Given this list of marker genes Pfkfb2, Slc7a15, Csnk1d, Adam17, Prmt2, Dhrs11, Vat1, Adgre4, Pom121 (nuclear pore membrane protein 121), Zfp956, 2410004B18Rik, Fbln1, Acly, Spo11, Ifnlr1 (interferon lambda receptor 1), Mbd6, Strn, Rbm33 (NCBI Gene Id 72420), Polk, Zfp329, Arhgap21, Pxk, Snn, Vdac2, Tbc1d5, Acad11, Rassf8, Cks2, 2610008E11Rik, Atxn7l1, Arfgef1, Kalrn, Tmpo, Fiz1, Phf21a, Luc7l3, Wee1, Lypd6, Jak1, Mia3 (NCBI Gene Id 98575), Vkorc1l1, Abt1, Shisa8, Bnipl (BCL2/adenovirus E1B 19kD interacting protein like), Spred3, Cdkl2, Ebna1bp2, Txndc8, Eya1, Zbtb26, Aldh5a1 (NCBI Gene Id 74423), Vps35, Man1a2, Zfp236, Ndrg2 (N-myc downstream regulated gene 2), Rap1b, Agps, Gpr141b, Chd1, Smcr8, Ppp1r9a, Jam2, Cert1, Plat, Serpina3b, Sez6l, Zcchc2, Cbll1, Dnaja2, Fam91a1, Pcmtd2, Rit1, Sh3gl3, Angptl7, Napg, 1700029F12Rik, Map4k5, Mavs, Rgs16, Morc3, Necap1, Tmem33, Klhl9, Lhfpl2, Gga3, Atad2b, Gcnt3, Fbxl3, Il23a, Lin52 (lin-52 DREAM MuvB core complex component), Arid5a, Agfg1, Luzp2, Pitpnm3, Kcnh1, Ikzf2, Cpsf6, Cyp1b1, Grsf1, Rlim, Kmt2a, Cdc42se2, Clk2, Tbc1d30, Ggnbp2, Prkcsh, Rnf144a, Spin2c (NCBI Gene Id 278240), Magea9, Eogt (EGF domain specific O-linked N-acetylglucosamine transferase), Taf8, Ei24, Trim30d, Stxbp3, Serpina7, Stk25, Itga6, Evl, Add3, Cdc14b, Blcap, Sting1, Mocs2, Wdr45b, Btg1, Sds, Zic4 (zinc finger protein of the cerebellum 4), Prkaa2, Prom1, Erbb4, Wnk3, Syde1, Tmppe, Ubap1, Npas3, Neurod1, Evi5, Ptprk, Med13l, Mcm2, Ric3, Rdh10, Mex3c, Zfp462, Edem1, Rrs1, Ubn1, Hhat, Fbxo10, Elk3, Gm4884, Ajap1, Pik3cb, Dpysl2, Pogz, Efna5, Rfxap, Brd8, Bmt2, Qki, 9130008F23Rik, Ythdf3 (NCBI Gene Id 71600), Pnma1, 4931406C07Rik, Tle4, Ldhb, Myo9a, here is a description of the gene set: Genes predicted to be targets of miRBase v22 microRNA mmu_miR_12196_3p in miRDB v6.0 with MirTarget v4 prediction scores > 80 (high confidence targets). studied in species Mus musculus Mouse Gene Set: MIR_12196_3P from publication Chen Y, Wang X (PMID 31504780)